Given this list of marker genes COX6C, PLAG1, TCEA1, FGFR1, KAT6A, NSD3, PCM1, WRN (WRN RecQ like helicase), here is a description of the gene set: Amplification hot spot 9: colocolized fragile sites and cancer genes in the 8p23-q12; 8q23 region. DNA copy number amplifications activate oncogenes and are hallmarks of nearly all advanced tumors. Amplified genes represent attractive targets for therapy, diagnostics and prognostics. To investigate DNA amplifications in different neoplasms, we performed a bibliomics survey using 838 published chromosomal comparative genomic hybridization studies and collected amplification data at chromosome band resolution from more than 4500 cases. Amplification profiles were determined for 73 distinct neoplasms. Neoplasms were clustered according to the amplification profiles, and frequently amplified chromosomal loci (amplification hot spots) were identified using computational modeling. To investigate the site specificity and mechanisms of gene amplifications, colocalization of amplification hot spots, cancer genes, fragile sites, virus integration sites and gene size cohorts were tested in a statistical framework. Amplification-based clustering demonstrated that cancers with similar etiology, cell-of-origin or topographical location have a tendency to obtain convergent amplification profiles. The identified amplification hot spots were colocalized with the known fragile sites, cancer genes and virus integration sites, but global statistical significance could not be ascertained. Large genes were significantly overrepresented on the fragile sites and the reported amplification hot spots. These findings indicate that amplifications are selected in the cancer tissue environment according to the qualitative traits and localization of cancer genes. from publication Myllykangas S, Himberg J, Böhling T, Nagy B, Hollmén J, Knuutila S (PMID 16751803) Human Gene Set: MYLLYKANGAS_AMPLIFICATION_HOT_SPOT_9 species: Homo sapiens